The following is a description of a gene set: species: Mus musculus Mouse Gene Set: GOBP_AUTOCRINE_SIGNALING Signaling between cells of the same type. The signal produced by the signaling cell binds to a receptor on, and affects a cell of the same type., and this is the list of marker genes: Cx3cr1, S100a8, Cx3cl1, Fzd1, Gm5849, S100a9, Hilpda, Cd68